Given this list of marker genes CDKN2C, CDKN1B, MEN1, CDKN2B, CDKN1A, here is a description of the gene set: Thymoma A tumor originating from the epithelial cells of the thymus. Human Gene Set: HP_THYMOMA species: Homo sapiens